Given this list of marker genes RPL39, IFNW1, RARRES2, HPX, BCL3, FCN3, C6, DEFA1B, NTS, CFHR2, CCL8, CCL3, CCL11, S100A7, C4BPA, DEFB127, CXCL9, CD5L, CR2 (complement C3d receptor 2), RNASE7 (ribonuclease A family member 7), TREM1, CCL1, CR1L, S100A12, RNASE4, BLNK, MIR520E, CD37, FCGR2B (Fc gamma receptor IIb), MASP1, APP, IGHE, SUSD4, CFHR5, CFHR1, IL36RN, PGLYRP4, IGHA1, CCL27, MUC7, IFNA10 (interferon alpha 10), H2BC10, CCL18, FCMR, GAPDH, IGKV3-20, SEMG2, IFNK, WFDC3, ELANE, IGHG2, XCL1, CD59, DEFA6, NOTCH1, CCL4, WFDC10B, TRAF3IP2, CCL25, CD28 (CD28 molecule), IL6, EVPL, DCD, CCL23, PPP2R3C, MIR520B, CALCA, PRSS2, LTA, FAU, C7, BPIFA1 (NCBI Gene Id 51297), C8A, CXCL14 (C-X-C motif chemokine ligand 14), SPINK5, KLK5, KRT6A, MASP2, TSLP, TREM2, CCL20, C2, PLA2G1B (phospholipase A2 group IB), LEAP2, CCL28, CTSG, SLPI, BPI, CCL7, GATA6, HLA-A, IFNA16, MEF2C, NPPB, C1R, H2BC12L, ROMO1, TFEB, ANG, JCHAIN, CCL13, CCL4L2, CCL15, TAC1, CCL22, CR1, CFHR3 (complement factor H related 3), SPAG11B, TFE3, PHB2, AZU1, GPI, PGC, C1RL, IFNA17, GNLY, HTN3, CXCL6, HLA-DRB1, C4BPB, ADM, CCR2, H2BC11, DEFA1, PI3, LTF, DEFB131A, ACOD1, DEFB118, HMGN2, IGHA2, CCL26, IFNE, HLA-DQB1, LYZ, IFNA5, SPON2, PRSS3, FCER2, PPBP, MMP7, CCR7, TNF, FAM3A, WFDC11, H2BC7, CXCL10, HLA-E, VSIG4, C1S, EBI3, DEFA5, PGLYRP1, ZP4, RBPJ, CXCL12, HTN1, IFNA8, IGHG3, H2BC12, CCL24, DMBT1, CCL2, DEFA4, HRG, IFNA21, BST1, FOXJ1, LGALS4, POMC, GPR183, COLEC10, DEFB126, IFNG, KLK7, SERPING1, POU2F2, IFNA1, RNASE6, RPS19, SPRR2A, C1QC, CFB, SLC11A1, PGLYRP3, BCL2, FCN1, A2M, CCL5, CCL17, IGHG4, H2BC8, SH2D1A, CCL16, TOR2A, CFD (NCBI Gene Id 1675), REG3G, DEFB4A, DEFB103B, CFI, PHB1, GALP, CFHR4, PTPN6, KRT1, KLK3, C9, SEMG1, IFNA6, CCR6, MS4A1, WFDC13, MBL2, PLA2G6, DEFB103A, IGHG1, CD55, H2BC21, GATA3, CXCL5, LGALS3, C8B, IFNB1, WFDC10A, CXCL11, CCL14, VIP, FCN2, PF4V1, POU2AF1, RNASE2, CST9, CXCL1, IFNA2, CX3CL1, C1QB, CST9L, DEFB130A, RPL30, XCL2, CAMP, IFNA4, TNFRSF21, WFDC12, H2BC4, IGHD, IL1B, YTHDF2, KNG1, IFNA7, AIRE, DEFB1, REG1B, DEFA3, NOTCH2, HAMP, CXCL2 (C-X-C motif chemokine ligand 2), EXO1, NPY, WFDC9, F2, CFH, ZP3, COLEC11, BMI1, IL17A, C1QBP, S100A9 (NCBI Gene Id 6280), CCL21, CD46, CD81, C8G, CCL3L3, RNASE3, FGA, C3, CXCL8, CCL19, PRTN3, WFDC2, CXCL3, CFP, REG3A, IGHM, B2M, PDCD1, C4B, WFDC5, C5, ALOX5, CLU (clusterin), PSMB10, PF4, C1QA, PTPRC, REG1A, H2BC6 (H2B clustered histone 6), IL7, IL17F, TF, CD83, CXCL13, SPNS2, FGB, C4A, CST9LP1, IFNA14, here is a description of the gene set: studied in species Homo sapiens Human Gene Set: GOBP_HUMORAL_IMMUNE_RESPONSE An immune response mediated through a body fluid.